Given this list of marker genes Psenen, Aph1b, Mmp16 (matrix metallopeptidase 16), Timp2, Timp1, Psen1 (NCBI Gene Id 19164), Mmp14 (NCBI Gene Id 17387), Ncstn (NCBI Gene Id 68116), Tgfbr3, Aph1a, here is a description of the gene set: TGFBR3 PTM regulation species: Mus musculus Mouse Gene Set: REACTOME_TGFBR3_PTM_REGULATION